The following is a description of a gene set: Mouse Gene Set: GOCC_RIPOPTOSOME A protein complex whose core components are the receptor-interacting serine/threonine-protein kinases RIPK1 and RIPK3 (also called RIP1 and RIP3). Formation of the ripoptosome can induce an extrinsic apoptotic signaling pathway or a necroptotic signaling pathway. The composition of this protein complex may depend on several factors including nature of the signal, cell type and more. species: Mus musculus, and this is the list of marker genes: Ticam1, Cflar, Fadd, Casp8, Ripk1 (NCBI Gene Id 328217)